The following is a description of a gene set: Mouse Gene Set: GOBP_NEGATIVE_REGULATION_OF_CELLULAR_EXTRAVASATION studied in species Mus musculus Any process that stops, prevents, or reduces the frequency, rate, or extent of cellular extravasation., and this is the list of marker genes: Ccl21a, Ccl21e, Plcb1, Ccl21b, Ptger4, Bcr, Il27ra, Ccl28, Ccl21f, Cxcl12, Ccl25, Abr, Ccl21d